Given this list of marker genes ZNF143, ACTMAP, MEGF6, LINC02371, PPP6R1, GABPB2, RIGI, SLC6A6, RNASEK-C17orf49, VTRNA1-2, DLX4, DOC2A, DYNC2I2, PSMA3-AS1, C14orf93, CYB5A, PURPL, MLLT11, NAB2, FGD2, FAM117B, ARID4A, CNOT1, RNASEK, TMEM248, LAMP1, NACA, CYREN, RPL32P3, SRSF3, RAB40B, POLR1B, UCP2, SMIM30, ENSG00000269954, ABCG1, DGCR8, SNRPA, ASF1A, NEMP1, EPB41L4B, ARMCX4, TMEM204, PRR29-AS1, PNPLA8, UPF3A, CDK4, ENSG00000233017, RHBDF1, FNDC3A, GCC2, PLCL1, LINC03068, RAB5B, SYNGAP1, ARMH4, TFDP1 (transcription factor Dp-1), KAT5, SNRPEP4, SAP30-DT, FSD1, NR1I2, PPP4R3A, RNU6ATAC, MX1, TWF2-DT, TRIM62, EIF5B, GNA15, CGREF1, CDC42SE1, PRSS2 (NCBI Gene Id 93431), HLA-DMB, FKBP14-AS1, MAFF, FNBP4, SAP30, DVL2, RAD9A, GET4, CSF2RB, PLEKHB1, ITGB2, COL5A1, DHRS13, PREPL, CAMKMT, TXNDC9, ADGRG1, CELF4, here is a description of the gene set: from publication Yevshin I, Sharipov R, Kolmykov S, Kondrakhin Y, Kolpakov F (PMID 30445619) Genes containing one or more binding sites for (PAX8) in their promoter regions (TSS -1000,+100 bp) as identified by GTRD version 20.06 ChIP-seq harmonization. species: Homo sapiens Human Gene Set: PAX8_TARGET_GENES